Given this list of marker genes GLG1, S100A13, FGFR2, KL, ITGAV, KLB, FGFRL1, SCN5A, CXCL13, FGFBP3, RPS19, FGFR1, TGFBR3, CEP57, FGFBP1, FGFR4, FGFR3, ITGB3, FIBP, API5, THBS1, GPC1, RPS2, here is a description of the gene set: Human Gene Set: GOMF_FIBROBLAST_GROWTH_FACTOR_BINDING species: Homo sapiens Binding to a fibroblast growth factor.